Given this list of marker genes WBP11, NFIC, LAGE3, MTSS1 (MTSS I-BAR domain containing 1), ARRDC1, CUTA, PPP1R21 (NCBI Gene Id 129285), MLEC, HAUS4, SSNA1, ODR4, SKI, ADD1, CRAT, AIRN, TSPAN4, NOP2, WDR75, CCDC115, EPN1, PHKG2, PDXK, NCKIPSD, ETFRF1, MKNK2, MCFD2, AIF1, IDH1, TMX2, PIP4P2, TMEM131, MRPS23, SRPK2, CHST12, TGFBR1, SLC35C2 (solute carrier family 35 member C2), PRCP, CAMK1D, SPTSSA, GRAMD4, UNC119, ANGPTL4, UBAC1, GPSM3 (G protein signaling modulator 3), TPCN1, ABL1, PLEKHA1, MAGEE1 (MAGE family member E1), ERLIN1, ITPR1, PALD1, COQ8B, HAUS8, NAAA, PNPO, CRIP1, GNL3, KIAA0930 (NCBI Gene Id 50610), PIP4K2C, STT3B, VPS53, MRPL47, ZNF703, ALG2, TIMM44, HS2ST1, HMGA1, MRPS16, PPP1R14B, GGNBP2, MANBA, ATG3, MKNK1, RBM39, SMYD2, ABCG1, ARRB1, QRSL1, VOPP1, BCAS2, SLA, BLTP3A, GSN, CIITA, ZMYND8, ZFYVE19, NFATC3, OCEL1, MYO18A, SORT1, HAUS3, DMAC1, MCM4, GALC, POLD1, TIMM8A, SP1, TPRA1, TIMM50, TPCN2, AURKB, SDF2L1, TMEM37, CTDNEP1, AHCYL2, CIB1, PTGS1, TBL1XR1, SMC6, ADIPOR2 (adiponectin receptor 2, NCBI Gene Id 84751), SLC25A15, TNPO1, NDUFS3, UCK2, TBC1D14, LZTR1, MMACHC, TEF, ZNF706, SURF1, FAAP20, MYO9B, CDC20, MTHFD1, MAST3, SNX3, KIF2A, HEMK1, EPB41L1 (erythrocyte membrane protein band 4.1 like 1), AFG1L, MRTFA, PPP1CA, TGFBR2, TOP2B, ARHGAP9, MTA3, SELENBP1, PJA1, SSBP2 (single stranded DNA binding protein 2), KIF18A (kinesin family member 18A), CLUH, IRAG2, ARPC1B, ZBTB20, KLHL22, NCOR2, STAB1, POLR2I, TXN2 (thioredoxin 2), DDX18, FCGR2A (NCBI Gene Id 90764), GOLM1, TPD52, CDK4, ADAM19 (NCBI Gene Id 8728), IQGAP2, PSMG2, GNB5, ITCH, APPL2, LFNG, PNPLA7, ADAM10, EVI2B, IMPA2, DGKA, AHSA1, SLC25A39, CD300C, HSD17B4, VIPAS39, TBC1D20, SENP3, DUSP3, TRIM41, CASP9, TTC27, GPR180, ADCY7, ICA1, MRPS26 (mitochondrial ribosomal protein S26), PDCD6, POLR2E, PEX6, COPRS, CORO2A, TEX264, RRM2, DNMT1, MICAL1, RAB40C, GPR65, RPA1, PHF7, BACE1, SMC3, EIF4EBP2, CDKAL1, AURKA, HMGCL, here is a description of the gene set: Genes up-regulated in comparison of dendritic cells (DC) stimulated with CpG DNA (TLR9 agonist) at 0.5 h versus those stimulated with CpG DNA (TLR9 agonist) at 4 h. species: Homo sapiens Human Gene Set: GSE17721_0.5H_VS_4H_CPG_BMDC_UP mouse primary BMDCs were stimulated with tlr ligands and gene expression changes were profiled on Affymetrix arrays from publication Amit I, Garber M, Chevrier N, Leite AP, Donner Y, Eisenhaure T, Guttman M, Grenier JK, Li W, Zuk O, Schubert LA, Birditt B, Shay T, Goren A, Zhang X, Smith Z, Deering R, McDonald RC, Cabili M, Bernstein BE, Rinn JL, Meissner A, Root DE, Hacohen N, Regev A (PMID 19729616)